The following is a description of a gene set: Mouse Gene Set: GOBP_ZYGOTIC_DETERMINATION_OF_ANTERIOR_POSTERIOR_AXIS_EMBRYO species: Mus musculus The specification of the anterior/posterior axis of the embryo by products of genes expressed in the zygote; exemplified in insects by the gap genes, pair rule genes and segment polarity gene cascade., and this is the list of marker genes: Nckap1, Pcsk6, Neurog1, Wt1, Tifab